Given this list of marker genes NCOR1, HDAC4, MAML3, NOTCH2, SNW1, HDAC6, NCOR2, TBL1X, MAMLD1, MAML2, HDAC9, HDAC2, NOTCH1, NOTCH3, HDAC5, HDAC11, NOTCH4, KAT2A, HDAC7, KAT2B, TBL1XR1, MAML1, HDAC8, HDAC3, HDAC1, HDAC10, CREBBP (NCBI Gene Id 1387), RBPJ, here is a description of the gene set: <b>THE NOTCH-HLH TRANSCRIPTION PATHWAY:</b> <br><br> Notch signaling was first identified in Drosophila, where it has been studied in detail at the genetic, molecular, biochemical and cellular levels. In Drosophila, Notch signaling to the nucleus is thought always to be mediated by one specific DNA binding transcription factor, Suppressor of Hairless. In mammals, the homologous genes are called CBF1 (or RBPJkappa), while in worms they are called Lag-1, so that the acronym "CSL" has been given to this conserved transcription factor family. There are at least two human CSL homologues, which are now named RBPJ and RBPJL.<br><br>CSL is an example of a bifunctional DNA-binding transcription factor that mediates repression of specific target genes in one context, but activation of the same targets in another context. This bifunctionality is mediated by the association of specific Co-Repressor complexes vs. specific Co-Activator complexes in different contexts, namely in the absence or presence of Notch signaling.<br><br>In Drosophila, Su(H) represses target gene transcription in the absence of Notch signaling, but activates target genes during Notch signaling. At least some of the mammalian CSL homologues are believed also to be bifunctional, and to mediate target gene repression in the absence of Notch signaling, and activation in the presence of Notch signaling.<br><br>Notch Co-Activator and Co-Repressor complexes: This repression is mediated by at least one specific co-repressor complexes (Co-R) bound to CSL in the absence of Notch signaling. In Drosophila, this co-repressor complex consists of at least three distinct co-repressor proteins: Hairless, Groucho, and dCtBP (Drosophila C-terminal Binding Protein). Hairless has been show to bind directly to Su(H), and Groucho and dCtBP have been shown to bind directly to Hairless. All three of the co-repressor proteins have been shown to be necessary for proper gene regulation during Notch signaling in vivo.<br><br>In mammals, the same general pathway and mechanisms are observed, where CSL proteins are bifunctional DNA binding transcription factors (TFs), that bind to Co-Repressor complexes to mediate repression in the absence of Notch signaling, and bind to Co-Activator complexes to mediate activation in the presence of Notch signaling. However, in mammals, there may be multiple co-repressor complexes, rather than the single Hairless co-repressor complex that has been observed in Drosophila. <br><br>During Notch signaling in all systems, the Notch transmembrane receptor is cleaved and the Notch intracellular domain (NICD) translocates to the nucleus, where it there functions as a specific transcription co-activator for CSL proteins. In the nucleus, NICD replaces the Co-R complex bound to CSL, thus resulting in de-repression of Notch target genes in the nucleus. Once bound to CSL, NICD and CSL proteins recruit an additional co-activator protein, Mastermind, to form a CSL-NICD-Mam ternary co-activator (Co-A) complex. This Co-A complex was initially thought to be sufficient to mediate activation of at least some Notch target genes. However, there now is evidence that still other co-activators and additional DNA-binding transcription factors are required in at least some contexts.<br><br>Mammalian CSL Corepressor Complexes: In the absence of activated Notch signaling, DNA-bound CSL proteins recruit a corepressor complex to maintain target genes in the repressed state until Notch is specifically activated. The mammalian corepressor complexes include NCOR complexes, but may also include additional corepressor proteins, such as SHARP. The exact composition of the CSL NCOR complex is not known, but in other pathways the "core" NCOR corepressor complex includes at least one NCOR protein (NCOR1, NCOR2, CIR), one Histone Deacetylase protein (HDAC1, HDAC2, HDAC3, etc), and one TBL1 protein (TBL1X, TBL1XR1). In some contexts, the core NCOR corepressor complex may also recruit additional corepressor proteins or complexes, such as the SIN3 complex, which consists of SIN3 (SIN3A, SIN3B), and SAP30, or other SIN3-associated proteins. An additional CSL - NCOR binding corepressor, SHARP, may also contribute to the CSL corepressor complex in some contexts. The CSL corepressor complex also includes a bifunctional cofactor, SKIP, that is present in both CSL corepressor complexes and CSL coactivator complexes, and may function in the binding of NICD and displacement of the corepressor complex during activated Notch signaling.<br><br>Mammalian CSL Coactivator Complexes: Upon activation of Notch signaling, cleavage of the transmembrane Notch receptor releases the Notch Intracellular Domain (NICD), which translocates to the nucleus, where it binds to CSL and displaces the corepressor complex from CSL. The resulting CSL-NICD "binary complex" then recruits an additional coactivator, Mastermind (Mam), to form a ternary complex. The ternary complex then recruits additional, more general coactivators, such as CREB Binding Protein (CBP), or the related p300 coactivator, and a number of Histone Acetytransferase (HAT) proteins, including GCN5 and PCAF. There is evidence that Mam also can subsequently recruit specific kinases that phosphorylate NICD, to downregulate its function and turn off Notch signaling.<br><br>Combinatorial Complexity in Transcription Cofactor Complexes: HDAC9 has at least 7 splice isoforms, with some having distinct interaction and functional properties. Isoforms 6 and 7 interact with NCOR1. Isoforms 1 and 4 interact with MEF2, which is a specific DNA-binding cofactor for a subset of HLH proteins. Isoform 3 interacts with both NCOR1 and MEF2. Although many HDACs only have one or two isoforms, this complexity for HDAC9 illustrates the level of transcript complexity and functional specificity that such "general" transcriptional cofactors can have. species: Homo sapiens Reactome Pathway: Notch-HLH transcription pathway part of: Generic Transcription Pathway